The following is a description of a gene set: Human Gene Set: GSE5099_MONOCYTE_VS_ALTERNATIVE_M2_MACROPHAGE_UP Genes up-regulated in monocytes versus alternatively activated (M2) macrophages. Monocytes mature tom acrophages in the presence of the lineage determining cytokine M-CSF. They can be further polarized into M1 or M2 macrophages with distinct functional properties. We used microarrays to detail the global programme of gene expression underlying macrophage maturation and polarization and identified distinct classes of up-regulated genes during this process. species: Homo sapiens from publication Martinez FO, Gordon S, Locati M, Mantovani A (PMID 17082649), and this is the list of marker genes: LSR, BTG2-DT, PDCD6P1, MAP4K2, ERVH48-1, FARSB, POLRMTP1, LRP8, SSX3, CCR6, IL34, ZNF846, LYPD8, NEFH (neurofilament heavy chain), ASH2L, IZUMO4, HSF2BP (NCBI Gene Id 11077, heat shock transcription factor 2 binding protein), RPP40, SNX8, STAG3L4, SCG2, COPRS, MMUT, IGLV4-3, NEURL1, IDNK, NQO1, OPA1, ANO7L1, TLR1, SNRPA1, RIMS1, CDH2, APOBEC3B, ERP27, DHRS12, NPM1, SAV1, RAB37, DIS3L, PRKG2, DCAF4 (NCBI Gene Id 26094), CCDC85A, AGA, TAF2, PRLH, CARS1, RBFA, GOLGA1, STYK1, P2RX4, ZNF771, SLC4A8, BATF3, TRPM3, F11, KLHDC7B, ERLEC1P1, DUXAP10, OLIG2, ZNF765, LINC02481, PDGFC, BCKDHA, PPEF1, SLC41A3, MAGEB2, A2ML1, FUS, DNASE1L1, RCAN3, NOL9, PIGH, ZFYVE26, PRSS27, RALYL, DLAT (NCBI Gene Id 1737), ABHD12, PTPRN2, SH2D5, NEFM, GARS1, CYP2F1, FFAR3, PARP2, RARB, EVC2, CAV2, WNK3, LTBR, NT5E, AMIGO3, OR8G2P, RABGGTB, TMED4, PDE8A, PIK3R2, LINC02232, H2BW2, RTN4IP1, SPR, HKDC1, PDRG1, NUCKS1, GAS5, SPATA24, OPRPN, POLR3K, SLPI, FDPS, EREG, LGALS2, SWSAP1, FBXO45, ENSG00000257545, BCDIN3D-AS1, RPS6KL1, DEF8, CYP2R1, ZBTB45, C8orf48, PCDHB2, AKIRIN2, CDH9, PTOV1-AS1, DGAT2, SDK2, PGAM2, DNAJC13, DHX58 (NCBI Gene Id 79132), CORIN, ISL2, ZNF70, RNF157-AS1, MGAT4C, FBXO4, DDX31, DACH2, GLIPR1L1, ZNF593, ABCG2, PRKX, BCL7B, LENEP, ZNF483, TRIM42, SEPTIN8, PHETA2, RNASEL, TP53BP2, LRRC72, COL7A1, CD93, CMC4, KIF23, CPSF4, C1RL-AS1, MAPK10, NIPSNAP1, NHSL2, NEK3, ATAD5, OR3A2, SOAT2, COL6A2, IL10RB-DT, NRTN, IFI16, GLB1L2, ADAM6, CFHR5, MAPKBP1, KRT23, RIPOR1, SCGB1A1, DDB2, C19orf47, LINC00922, SNHG17, CCDC159, SLFN13, IPP, GATAD1, DNAAF4, STRA6, SLC7A13, SNHG12, NTN5